The following is a description of a gene set: Hypomethylation of CpG dinucleotides in genomic DNA was one of the first somatic epigenetic alterations discovered in human cancers. DNA hypomethylation is postulated to occur very early in almost all human cancers, perhaps facilitating genetic instability and cancer initiation and progression. We therefore examined the nature, extent, and timing of DNA hypomethylation changes in human prostate cancer. Contrary to the prevailing view that global DNA hypomethylation changes occur extremely early in all human cancers, we show that reductions in (5me)C content in the genome occur very late in prostate cancer progression, appearing at a significant extent only at the stage of metastatic disease. Furthermore, we found that, whereas some LINE1 promoter hypomethylation does occur in primary prostate cancers compared with normal tissues, this LINE1 hypomethylation is significantly more pronounced in metastatic prostate cancer. Next, we carried out a tiered gene expression microarray and bisulfite genomic sequencing-based approach to identify genes that are silenced by CpG island methylation in normal prostate cells but become overexpressed in prostate cancer cells as a result of CpG island hypomethylation. Through this analysis, we show that a class of cancer testis antigen genes undergoes CpG island hypomethylation and overexpression in primary prostate cancers, but more so in metastatic prostate cancers. Finally, we show that DNA hypomethylation patterns are quite heterogeneous across different metastatic sites within the same patients. These findings provide evidence that DNA hypomethylation changes occur later in prostate carcinogenesis than the CpG island hypermethylation changes and occur heterogeneously during prostate cancer progression and metastatic dissemination. studied in species Homo sapiens Genes expressed in at least one prostate cancer cell line but not in normal prostate epithelial cells or stromal cells Human Gene Set: YEGNASUBRAMANIAN_PROSTATE_CANCER from publication Yegnasubramanian S, Haffner MC, Zhang Y, Gurel B, Cornish TC, Wu Z, Irizarry RA, Morgan J, Hicks J, DeWeese TL, Isaacs WB, Bova GS, De Marzo AM, Nelson WG (PMID 18974140), and this is the list of marker genes: CTH, MAGEA3, FOLH1, KLK3, SLC44A4, HOXB13, ACP3, ABHD2, EEF1A2, EXOSC4, GAS2, TSPY1, GCNT1, NEMP1, ALDH3A2, TSPAN8, EIF2S1, CRISP3, CENPN, PON1, CLCN4, UGT2B11, NKX3-1, KLHL7, SPINK1, GPM6A, MIA2, PAGE1, MYBL1, ELF5, AZGP1, TOX3, DNAAF2, GTF2F2, CLDN4, COCH, PDE10A, TIMM9, CTAG2, ALB, PEG3, ID4, PLAAT1, ZFX, TNNT1, ETV1, MAPKAPK5-AS1, LONP1, LYSET, SPDEF, SRSF6, PRAME, ST7, MANEA, PTPRB, DHFR, TRIM68, BCOR, ALDH6A1, ZNF780B, SSX3, ALAS1, SUPV3L1, ARHGEF26, SHTN1, AMACR, CTAG1B (NCBI Gene Id 88439), DHRS2, MCCC2, DDC, SORD, KIF23, KRT81, CLGN, MAGEA2, NEBL, PBLD, KDM6A, TRIM36, MAGEA5P, BCHE, MAGEA1, ATAD2, GAGE1, SCG3, UGT2B15, MAGEA4, HPGD, AGR2, EPHA3, KLK2, HPCAL1, PCDHA9, ADO, MAGEA12, CEP76, PSMC3IP, FECH, FGF13, SERPINA1 (serpin family A member 1), TPTE, DONSON, TRGC1, GPR37, XAGE1B, TMPRSS2, TFAM, OCLNP1, ARHGAP6, E2F5, CLDN3, ZSCAN31, CALML5, TMEM38B, SMCHD1, RLN1, PRSS2, SSX2, SLC25A21, RASA4 (NCBI Gene Id 10156), SLC39A8, DBT, NXF2, ZBTB10, MED6, NDC80, NCAM2, ECD, HMGN5, TBC1D31, SSX1, SLC43A1, ERBB3, BBS4, SOHLH2